The following is a description of a gene set: Mouse Gene Set: MIR_712_5P from publication Chen Y, Wang X (PMID 31504780) species: Mus musculus Genes predicted to be targets of miRBase v22 microRNA mmu_miR_712_5p in miRDB v6.0 with MirTarget v4 prediction scores > 80 (high confidence targets)., and this is the list of marker genes: Phb1, Moap1, Cgnl1, Tfpi2, Lamc1, Frk, Etnk1, Lpl, Atf7ip, Lum, Gm14322, Zfp558, Gkap1, Satb2, Sox7, Cdc27, Chga, Tnr (tenascin R), Cdh20, Eva1c, Gpr55, E2f5, Sertad2, Prpf39, Zfp518b, Arhgap26, Prkce, Loxl2, Fut10, Tmem68, Kit, Vangl1, Aldh8a1, Trim5, Ybx2, Hs3st1, Amer2, Wnk3, Tmem185b, Fgfrl1, Aadat, Hsd17b10, Eif2s3y, Zfp970, Il20ra, Tln2, Zc3h11a, Vstm5, Nek1, Tm9sf2, Scfd2, Esrrg, Lmna, Akna, Slc35d2, Gxylt1, Rab14, Ccnj, Dusp7, Ago1, Chmp5, 4930579G24Rik, Pde7a, Zfp654, Fam168a (NCBI Gene Id 69223), Ptprm, Sel1l, Slc7a6, Csf1, Aff1, Rtn3, Cltc, Ubn2, Xxylt1, Wdr4, Pgm2l1, Mmut, Cpsf6, Nf1, Slc17a8, Serpinb2, Afdn, Phf11d, Zfp775, Elapor2, Gm14325, Sox1, Gm14391, Gpr161, Tbc1d32, Sema7a, Nsf, Asb5 (NCBI Gene Id 76294), Snx30 (sorting nexin family member 30), Rngtt (NCBI Gene Id 24018), Acsl1, Gm14137, Gm6710, Tomm70a, Mprip, Cmtm4, H2-M2, Nol3, Ssbp3, Vash2, Tnrc18, Dennd6a, Bbof1, Pramel57, Plcb1 (phospholipase C, beta 1), Dnal1, Ranbp17, Ankrd13c, Zfp58, Nnmt (NCBI Gene Id 18113), Axin2, Pcdhb19 (NCBI Gene Id 93890), Mgrn1, Rgs6, Dclk1, Sorbs1, Lysmd3, Kmt2a, Lrp1, Atp6v1g1, Psd3, Rora, Spmip9, Tnfsf15, Cdan1, Lysmd4, Gm14434 (predicted gene 14434), Ptprn2, Negr1, Vti1b, Rfk, Btbd3, Ddx52, Katnal1, Cd244a, Lrch3, Amigo2, Gars1, Aak1, Lrrn4, Gm4724, Taok1, Gm2026, Crmp1, Hnrnph3, Kctd8, Pcdh15, Ecd, 1110038F14Rik, Gm14326 (NCBI Gene Id 665211), Adgrf5, Erbb4, Hs3st4, Chn1, Rnf130, Ppp3r1, Capza1, Ptprj, Calu, B3gnt6, Stk3, Cpeb2, Dcaf10, Pum1, Gm14308, Eif1a, Tpbg (NCBI Gene Id 264331), Vasn, Trak2, Pramel55, Lrrk2, Strbp, Mosmo, Tmem130, Rab3c, Rnf144a (NCBI Gene Id 24106), Stat4, Nup42, Irf2bpl, Sdha, Mfng, Zfp971, Ppp1r3a, Golm2, Zeb2, Cldn11, Zfp800, Gosr2, Cdk19, Mon2, Atxn7, Mier3, Eef1b2, Map3k13, Pakap, Rapgef4 (Rap guanine nucleotide exchange factor (GEF) 4), Wdtc1, Fermt2, Aebp2